Given this list of marker genes Tmem30a, Slc35d3 (NCBI Gene Id 76157), Tm9sf4, Slc51b (solute carrier family 51, beta subunit), Sec16b, Cd81, Sorl1, Edem2, Tmem30b, Edem1, Bcap31, here is a description of the gene set: Mouse Gene Set: GOBP_POSITIVE_REGULATION_OF_PROTEIN_EXIT_FROM_ENDOPLASMIC_RETICULUM Any process that activates or increases the frequency, rate or extent of directed movement of proteins from the endoplasmic reticulum. species: Mus musculus